Given this list of marker genes ABCC4, SELP, ITPR1, CD63, RAB27B, LAMP2, here is a description of the gene set: The lipid bilayer surrounding the platelet dense granule. Human Gene Set: GOCC_PLATELET_DENSE_GRANULE_MEMBRANE studied in species Homo sapiens